Given this list of marker genes FGF5 (fibroblast growth factor 5), FGF20, KRAS, FGF17, FGF3, FGF2, FGF1, FGF22, SOS1, FGF9, GRB2, NRAS, KL, FGF6, FGFR1, HRAS, FGF23, FGF10, FGF8, SHC1, FGF4, here is a description of the gene set: Reactome Pathway: SHC-mediated cascade:FGFR1 The exact role of SHC1 in FGFR signaling remains unclear. Numerous studies have shown that the p46 and p52 isoforms of SHC1 are phosphorylated in response to FGF stimulation, but direct interaction with the receptor has not been demonstrated. Co-precipitation of p46 and p52 with the FGFR2 IIIc receptor has been reported, but this interaction is thought to be indirect, possibly mediated by SRC. Consistent with this, co-precipitation of SHC1 and FGFR1 IIIc is seen in mammalian cells expressing v-SRC. The p66 isoform of SHC1 has also been co-precipitated with FGFR3, but this occurs independently of receptor stimulation, and the p66 isoform not been shown to undergo FGF-dependent phosphorylation. SHC1 has been shown to associate with GRB2 and SOS1 in response to FGF stimulation, suggesting that the recruitment of SHC1 may contribute to activation of the MAPK cascade downstream of FGFR. studied in species Homo sapiens part of: Downstream signaling of activated FGFR1